The following is a description of a gene set: Mouse Gene Set: GOBP_POSITIVE_REGULATION_OF_ACTIN_FILAMENT_BUNDLE_ASSEMBLY studied in species Mus musculus Any process that activates or increases the frequency, rate or extent of the assembly of actin filament bundles., and this is the list of marker genes: Pfn5, Rock2, Rapgef3, Itgb1bp1, Kiss1r, Fermt2, Fhod1, Mtor (NCBI Gene Id 80612), S100a10, Tsc1, Myoc, Abl1, Nrp1, Ccn2, Bag4, Vil1, Swap70, Synpo, Sh3pxd2b, Tac1, Wnt4, Tgfbr1 (transforming growth factor, beta receptor I), Pfn3, Nox4, Nf2, Pfn2, Synpo2l, Ppm1e (NCBI Gene Id 327991), Lpar1, Id1, Flna (NCBI Gene Id 245705), Limk1, Tgfb3, Synpo2, Braf, Epha1, Gpr65, Cx3cl1, Cd47, Pdlim4, Tacr1, Arhgef5, Cdc42, Arhgef15, Ppm1f, Rhoc (ras homolog family member C), Arhgef10, Mtss1, Carmil1, Tesk1, Sdc4, Ccdc88a, Tpm1, Serpinf2, Wnt11, Pfn1, Pak1, Limch1, Pxn, Rhoa, Rgcc, Sorbs3, Rac1, Smad3, Evl, Plek, Prkcq, Apoa1, Arhgef10l